The following is a description of a gene set: Binding to syndecan, an integral membrane proteoglycan (250-300 kDa) associated largely with epithelial cells. species: Mus musculus Mouse Gene Set: GOMF_SYNDECAN_BINDING, and this is the list of marker genes: Tnc, Chrd, Gpnmb, Psg22, Nf1, Sdcbp (NCBI Gene Id 53378), Hpse, Sema5a, Ptn